The following is a description of a gene set: Genes having at least one occurrence of the motif NNNTGACAGNNN in the regions spanning 4 kb centered on their transcription starting sites. This matches the MEIS1 transcription factor binding site V$MEIS1_01 (v7.4 TRANSFAC). Human Gene Set: MEIS1_01 species: Homo sapiens, and this is the list of marker genes: DAP3, ELAVL4, KRTAP17-1, PPM1D, NEUROD2, ETV1, TGIF1 (NCBI Gene Id 91941), SLC25A12, DMC1, CMTM4, WNT2, MBD6, RSPRY1, GPHN, SOX14, WWC1, SKIDA1, DDIT3, KCNAB3, KLF5, FOS, TMEM109, HLX, TLK2 (NCBI Gene Id 11011), LRCH4, FOXP2, TLE1, NPPA, ARRDC4, FBXO5, PDZRN4, PLAGL2, TNKS1BP1, IL17RC, ABL2, ZNF485, DNASE2B, SREBF2 (sterol regulatory element binding transcription factor 2), ITCH, SORBS1, SMPD3, DYNLRB2, ASH1L, TNKS, ENSA, SSBP4, KLF7 (KLF transcription factor 7), CDKN2C, GLI1 (GLI family zinc finger 1), LHX9, TMEM59, VILL, SMOC1, SPINK5, ARHGAP30, KRT2, SPRED1, HMGN2P46, C8orf17, FBXW7, ERRFI1, PPARGC1B, NPEPPS, C1orf43, GAB2, PCBP4, RPS6KB1, NRG1, NCALD, NDP, TCEANC2, ZIC3, KLF10, CREB5, ETS1, SPOCK2, CBX4, TRIM55, RUNX1T1, GCAT, SOBP, HINT2 (NCBI Gene Id 84681), TMEM126B, DDX50, NCAM1, KAT5, FITM1, FOXI1 (forkhead box I1), CREBRF, KLB, SCUBE3, CTSK, GRM6, BEND4, RBFOX1, EPHB2, CCN4 (cellular communication network factor 4), SMPX, SLC22A8, LINC01565, LHX1, MAPT, DMXL1, KCTD7, H1-0, VPS18, LINC00173, ANK2, RSF1, AMER1, SIRT1, CABP5 (NCBI Gene Id 56344), LIN28A, SS18, H2AZ1, TNPO1, RSBN1, MGAT4C, POU2AF1, IKZF5, PBRM1, TNIP1, HEPH, DNAJB5, CD248, KLF14, ABI3BP, DCAF17, PSMA6, ADCY8, MYLK2, PLCD1, EPG5, DIP2B, HCRTR2, ARMCX3 (NCBI Gene Id 51566), THRA, ACADSB, COL11A1, CKAP4, PLXNA2, YARS1, RLIM, LINC03124, DOK7, TGIF2, CLTC, TMIGD1, KCNQ5, LPCAT3, AAMDC (NCBI Gene Id 79737), TIAM1, TIMP4, USP15, LCOR (NCBI Gene Id 93376, ligand dependent nuclear receptor corepressor), SLC23A2, RBX1, ARFGAP3, COPZ2, NEUROD4, FBXO24, HOXB2, PPP2R2B, B3GALT2, DENND4A, DPF3, N6AMT1, TMEM71, ERCC8, SAMD11, PHLDB1, NYX, ATL1, BAZ1A (bromodomain adjacent to zinc finger domain 1A), STK3, NSL1, CNOT2, STX4, CLTRN, SEMA4A, GHDC, CXXC5, HSD11B1, GPR156, GARRE1, MEOX2, MYT1, AKIRIN2, EYA1, EN1, SPAG9, PIK3R3, STK40, HOXA1, PSIP1, CLN3, DYNC1I1, FRMD6, RANBP3L (RAN binding protein 3 like), SNAI1, KIRREL3-AS3, CDK17, HTR7, TGM7, NRP1, PPP3CA, TNFRSF19, PSME3IP1, SLC25A25, FGF12, ESRRG, NDUFAF2, PIM2, USP32, FKBP3 (FKBP prolyl isomerase 3), PDZD7, METTL8, GRIK3, CTNNBIP1, YY1AP1, MRGPRF, STT3B, NHLH2, ABCG4, FGF13, AP2M1, RGS6, ARFGAP2, UST, YIPF4, SPAG8, TCF7L2, CDKN2B, CDIN1, PSME3, POFUT1 (protein O-fucosyltransferase 1), ZMYND8, HES6, GRB7, NOL4, PAFAH1B1, CREB3L1, FLRT3 (NCBI Gene Id 23767), PITPNB, KIRREL3, SMDT1, GNAO1, FEZF2, EPB41